Given this list of marker genes Mbtps2, Plcd1 (NCBI Gene Id 97538), Sec14l2, Pou1f1, Fdps, Abcg4, Mas1, Gper1, Prkaca, Scap, Npy1r, P2ry6, Myh9, Ntsr1, Cd244a, Paqr3, Qki, Ptafr, Por, Bmp6 (NCBI Gene Id 28108), Adcyap1r1, Pth1r, Mapk1, Wnt4, P2ry1, Fgf1, Cyp7a1, Abcg1, Lhcgr, Avpr1b, Scp2, Srebf1, Snca, Dab2, Pth, Gnai1, Srebf2, here is a description of the gene set: studied in species Mus musculus Mouse Gene Set: GOBP_POSITIVE_REGULATION_OF_ALCOHOL_BIOSYNTHETIC_PROCESS Any process that activates or increases the frequency, rate or extent of alcohol biosynthetic process.